The following is a description of a gene set: Nephrin family interactions Mouse Gene Set: REACTOME_NEPHRIN_FAMILY_INTERACTIONS studied in species Mus musculus, and this is the list of marker genes: Nphs1, Nck2, Iqgap1, Kirrel3, Fyn, Kirrel1, Nphs2, Nck1, Kirrel2